Given this list of marker genes DDX6, FLACC1, CIMAP1A, AK1, CTSH, RSPH1, TMEM232, ODF1, here is a description of the gene set: A supramolecular fiber found in the flagella of mammalian sperm that surrounds the nine microtubule doublets. These dense fibers are stiff and noncontractile. In human, they consist of about 10 major and at least 15 minor proteins, where all major proteins are ODF1, ODF2 or ODF2-related proteins. Human Gene Set: GOCC_OUTER_DENSE_FIBER species: Homo sapiens